Given this list of marker genes MYH9, CD163, PLK2, IL6, MAPK14, FURIN, IL10, RHBDF2, ADAM17, here is a description of the gene set: CD163 mediating an anti-inflammatory response Human Gene Set: REACTOME_CD163_MEDIATING_AN_ANTI_INFLAMMATORY_RESPONSE species: Homo sapiens